The following is a description of a gene set: Human Gene Set: HP_TOENAIL_DYSPLASIA An abnormality of the development of the toenails. species: Homo sapiens Toenail dysplasia, and this is the list of marker genes: GJC2, TAF1 (TATA-box binding protein associated factor 1), FLT4, EVC, EOGT, SHANK3, TBC1D24 (TBC1 domain family member 24), BHLHA9, ATP6V1B2, EVC2, VEGFC, PIEZO1, LMX1B, BMP2, ANGPT2, TP63